The following is a description of a gene set: studied in species Homo sapiens Human Gene Set: PID_IL5_PATHWAY from publication Schaefer CF, Anthony K, Krupa S, Buchoff J, Day M, Hannay T, Buetow KH (PMID 18832364) IL5-mediated signaling events, and this is the list of marker genes: STAT5A, PIK3CA, GRB2, CISH, LYN, CSF2RB, SDCBP, PIM1, STAT5B (signal transducer and activator of transcription 5B), JAK2, IL5, IL5RA, PIK3R1, PTPN11